Given this list of marker genes TRPC1, TOP3A, NOTCH4, ZNF726, YIPF6, ARHGAP42, ARL6IP6, C2CD3, SYTL4, FERMT2, MYO6, ACVR1C, RANBP6, PTPN21, UBTD2, MAP3K9, SESN1, SLC22A4, ADCK2, EFCAB7, NFYA, FAM168B, DOP1B, SEC22A, FN3KRP, OAT, CAMK2N1, GCH1, CHAF1B, ULK4, EIF5A2, SPAG1, ADCY3, MOCOS, CEP126, CFAP20DC, GINS2, DOCK4, SLC4A7, ZNF75A, ANXA2R, PTER, ZNF646, PALB2, EPHX1, ARHGEF10, DDX47, BLOC1S5, PARP9, ING2, PANK2, APLNR, FRRS1, ARMC12, ELF2, LINS1, ZNF324, B4GALT6, KDSR (NCBI Gene Id 2531), UBQLN2, FPGT, LRCH1, RHBDL3, ARPC5, DENND11, TBC1D2B, TTLL7, MCM3, MPHOSPH8, PLSCR1, MCM10, XYLB, DCBLD1, ATP2B1, TXNRD3, KLHL22, ARMH4, FAM241A, KIAA0040, SLC25A24, CYLD (NCBI Gene Id 8010), THAP6, RFC4, CLTCL1, BRINP3, RNASEH2B, HYCC2, EAF2, ZDHHC21, AP3M2, GXYLT1, ABHD3, RGS2, RELL1 (RELT like 1), ITGB1BP1, ABI2, STK39, NAAA, TMEM80, CCN1, METTL15, TBCK, GPATCH11, PPM1K, GBX2, ARK2N, KANK2, OGDHL, PRXL2B, ZNF483, INTS7, RBBP8, MCIDAS, ALG10, SNX30, MMD, SBK1, DENND3, ZNF433, SH3BGRL2, ADGRA3, EPG5, GAB1, SYCP2, INSR (NCBI Gene Id 3643), VEZT, OSGIN2, DICER1, MBOAT1, DGCR8, RNF138, LRRCC1, MAK, ZNF620, FAM217B, HAMP, PLCG2, UFL1, TUBB4A (NCBI Gene Id 1864), DBR1, DCK, CD226, HCN3, ANKRD46, CROT, IQCC, USP37, PRPF38A, AFAP1, CAND1, ZFYVE19, FRG1, NR4A2, CAPRIN2, CCDC144NL, GKAP1, SOAT1, AKAP13, PLEKHH2, ETAA1, TIPIN, GDA, MAPRE2, ARGLU1, MTMR10, CDC25A, DSC2, ABHD11, SLC5A5, TFF1, HAUS2, GPD2, GPANK1, PEX1, PGM2L1, PDPK1 (NCBI Gene Id 5170), PHLPP1, DTX3L, TMEM161B, PCNA, RASL11B, DDAH1, SPICE1, TUFT1, ADAM22, RB1, TMEM168 (transmembrane protein 168), MCM5, EPB41L5, HAND2, RASD1, TIFA, PCGF6, MSH6, LPCAT1, SLC15A4, LATS2 (large tumor suppressor kinase 2), TLE4, IL1A, TP73, TMEM170B, GLCE, MEF2A (NCBI Gene Id 4205), ACD, TRIM45, TMEFF1, OXCT2, SYTL3, STRADB, PSMC3IP, BAG5, SPATA33, E2F2, TMEM223, CAND2, ZSCAN9, CCDC82, RAP2A, UXS1, NFIB, CHDH, RABGAP1L, TGFB3, HACE1, ARFGEF3, RMC1, ZNF367, DONSON, ANKRD26, KLF5, SERPINI1, HPF1, ZDHHC13, KCTD12, RBM11, TBC1D8, YRDC, ANAPC4, SFR1, ZBTB14, SPOPL, NHLRC3, SENP5, IGSF8, SETX, EFNB2, FKBP15 (NCBI Gene Id 23307), RXYLT1, ABHD5, GPR153, CFAP44 (NCBI Gene Id 55779), ACAD8, NPHP3, CNOT9, LAMP3, DSEL (dermatan sulfate epimerase like), HS3ST3B1, ATP6V1D, FAN1, WDCP, CHIC1, MCMBP, ALDH9A1, GPR155, CHD9, KBTBD8, NMT2, LINC01547, C3orf70, FMR1, MSX1, RFXAP, SAR1B, PKD2, CHAF1A, HS6ST1, MIS12, LTN1, PELI1, JAG1, DPYD, DCLRE1B, CCNE2, PAPOLB, RAPH1, TTC7A, GAGE1, UCK1, GPRASP2, STON1, MRM2, GINM1 (NCBI Gene Id 116254), POLR2C, GPR180, PRPF4, CDC14B, LRATD2, IFRD1, LONRF1 (LON peptidase N-terminal domain and ring finger 1), FOXO6 (forkhead box O6), ARHGAP28, NTAN1 (NCBI Gene Id 123803), ST3GAL1, INKA2, ID3, ADAM19, CDKN2AIP, ARMT1, ZNF594, FZD1, PRRG1, LBH, ATP1B1, DYNLT1, SLF2, HSF2, PHF3, AKTIP, EEPD1, MMUT, TRPA1, IFIH1, PRKAA2, CLSPN, DERL2, ISG20L2, MIER3, NAP1L5, TOPORS, AIDA, CASP7, HAT1, ULBP2, METTL9, FZD3, GCFC2, TOMM5, ISCA1, FHDC1, ATXN7, SPMAP2L, CPD, SVEP1, LNX1, TRIM52, LIMK2, GPS2, MANBA, TSHZ3, ERCC3, GJC1, OTULIN, MREG, TCAF1, KLF11, MACIR, TRPS1, DNAJC22, CDC6, ARHGAP10, MCPH1, DOP1A, SRPRA (NCBI Gene Id 94501), LANCL3, STARD3NL (NCBI Gene Id 83930), ACACB, HCFC2, PAX9, MAGEE1, TMC8, WNT9A, RALGPS2, CD40, SDE2, MTURN, LRATD1, PRKAB2, RNF121, STIM2, SFT2D2, MCM4, CNP, SYNJ1, SDCCAG8, FGD6, RNF144B, LRP11, RMI2, THYN1, REEP3, RHOBTB2, AZI2, L2HGDH, SP4, XRCC2, DMXL2, DYNC1I1, OTUD1, TRIM62, ICMT, LRRC42, STYX, IL10RA, SHOX2, GNPDA2, FAM210B (NCBI Gene Id 81895), FAM241B, CHRNA5, TDRD5, SAXO2 (NCBI Gene Id 283726), RUSC1, SLC38A9, PHF5A, BMP10, CREBL2, SLC30A10, DZIP1L, STK4 (serine/threonine kinase 4), WDFY3, IRAK4, TIRAP, POU3F2, MANEAL, HEBP1, KLHL8, USP13, APPL2, SCYL3 (SCY1 like pseudokinase 3), GPATCH1, PDE7A, SNIP1, DGCR6, LPCAT2 (NCBI Gene Id 54947), DLC1, HSPA14, CCNE1, DSG2, TAP1, SLF1, TMEM123, ZDHHC23, PRMT9, RAD9A, LMBRD2, SGTB, PMAIP1, FZD8, SESTD1, KHDRBS3, PARP14, PEX13, ASB3, IRX5, MFSD1, BRAP, MCUR1, ZNF519, TRPC3, TTC21B, CFAP69, USP46, RECQL, KLF13, TSSK3, MTRES1, SNAP29, SLC36A4, MMS22L, MET, NBEA, METTL25, NPAT, TMEM192, RMI1, APEX2, RAB6B, FMO5, WNK2, ANKEF1, C21orf91, MORN1, BPGM, CARHSP1, LIN52, ADIPOR1, LARGE1, RCOR3, PHLPP2, POLD3, KHDC1, RBM4B, DENND1B, HELLS, EXOSC9, SANBR, KLHL32, CDCA7, TRIM36, CSGALNACT2, ACSL6, PRDM2, ZDHHC6 (zinc finger DHHC-type palmitoyltransferase 6), GON7, NPC1, ZNF180, MEIS2, TEX15, L3MBTL3, AGBL3, ABCA5, SEPSECS, XRCC3, SEC24D, FOXA1, TMEM37, WDR76, ZFP90, NFYB, RAB23, FBXO4, DPM2, RAD51D, TCF7, TOM1L1, PNPLA8, STRN, DLG3, IL17RB, NBL1, CSTF3, EDA, DCLRE1A, HECA, OXR1, PTCH1, BTG3, TMTC3, ATP1B2, NGFR, SMIM13, PPP3CA, PPP2R3A, PLSCR4, MCM6, ASTE1, RTN4R, UBR7, CPEB2, ZNF442, PRKACB, WDR91, DTL, MTMR9, PTGER3, HFM1, TPD52L1, BTG2 (NCBI Gene Id 7832), PHF12, ATOSA, MANEA, FANCL, GNB5, EMSY, TMEM64, GGCT (gamma-glutamylcyclotransferase), PYGL, GAREM2, KCTD6, KIRREL2 (NCBI Gene Id 84063), MCM2, BCL9, LNX2, NXT2, KCNC4, STOM, DENND5B, NEK7, E2F1, SDR42E1, PARD6G, SYT10, COMMD8, TACC1, SMYD4, KCNAB2, UHRF2, STX7, WASF3, ZNF711, ZNF43 (zinc finger protein 43), APAF1, OGG1, FH, RMDN1, RAD54B, NFXL1, STK38L, UNC119B (unc-119 lipid binding chaperone B), SLC35G1, USP53 (ubiquitin specific peptidase 53), MAPK7, GLO1, LRRC28, GAREM1, SVIP, SCN1B, EXT1, SLBP, FOXD3, ITGAV, THAP9, LYSMD4 (LysM domain containing 4), MCM9 (NCBI Gene Id 54844), PASK, OLFM2, PCDHGB6, ZFR, LYNX1, PPAT, here is a description of the gene set: species: Homo sapiens Genes whose expression fluctuates during the cell cycle (pVal < 0.05) and peaks in G1/S transition (G1/S) in K562 Transcription regulation during the cell cycle is crucial for ensuring genes are expressed at the right time and in the correct amounts, coordinating key processes like DNA replication, mitosis, and cell division. In our study, Human Gene Set: PULVER_FOREY_CELLCYCLE_PEAKING_G1_S